The following is a description of a gene set: Mouse Gene Set: REACTOME_CA2_PATHWAY Ca2+ pathway studied in species Mus musculus, and this is the list of marker genes: Gng2, Tcf7, Pde6g, Gnb5, Gngt1, Tcf7l2, Gnao1, Gng10, Gng7, Gng8, Plcb1, Fzd6, Gng12, Ppp3ca, Gng3, Lef1, Map3k7, Wnt5a, Gnb3, Plcb2, Gng11, Fzd4, Wnt11, Gng4, Gng5, Tcf7l1, Plcb3, Calm2, Nlk, Camk2a, Gnb2, Gnat2, Calm1, Ppp3r1, Gnb4, Ppp3cb (protein phosphatase 3, catalytic subunit, beta isoform), Fzd5, Nfatc1, Pde6b, Gnb1, Ctnnb1, Calm3, Gng13, Gngt2, Kras, Fzd3, Fzd2 (NCBI Gene Id 57265)